Given this list of marker genes Slc20a1, Bhlhe40, Ncl, Anxa2, Nip7, Ctla2a, Abce1, Utp18, Zyx, Ybx3, Tpm4, Reps2, Syncrip, Cct2 (chaperonin containing TCP1 subunit 2), Hsph1, Snhg1, Gjb3, Idh3a, Tpm1, Mphosph6, Usp10, Ctu2, Wdr77, Nsun2, Mak16, Nuak1 (NCBI Gene Id 77976), Ppa1, Esd, Tnfrsf9, AU021092, Ddx21, Timp1, Cdk17, Uchl3, Dpy19l1, Naa25, Lyar, Cycs, Btbd10 (BTB domain containing 10), Myc, Zic4, Cct8, Eif4g1, Gars1, Nolc1 (nucleolar and coiled-body phosphoprotein 1), Pelo, Phgdh, Nae1, Zmiz1, Adissp, Bcat1, Wdr75 (WD repeat domain 75), Klf6, Bmp1, Nin, Rwdd1, Bag2, Tnfrsf12a (NCBI Gene Id 98086), Snx7, 1110038B12Rik, Mmp14 (NCBI Gene Id 17387), Rrm2, Gtf2f2, Msn, Naa15 (N(alpha)-acetyltransferase 15, NatA auxiliary subunit), Tomm20, Pmepa1, Lmln, Sltm, Eif5a, Cacybp, Pum3, Abracl, Ptk2, Eif3b, Pprc1, Gnl3, Ext1, Set, Rsl1d1, Hmga2, Eif2b3, Ptp4a1, Prep, Cdc34, Eif2s2, Cyp1b1, 2700038G22Rik, Kpnb1, Mrto4, Eif5, Actr3 (NCBI Gene Id 74117), Gemin6, Tcp1, Ccn2, Eef1e1, Jade1, Baz1a, Cd44, Ppp1r2, Chd3, Slc8a1, Hspd1, Eif3a, Gadd45g, Mir22hg, Coq10b, Actn1, Gtpbp4, Dlat, Lrp8, Arhgap26, Hspa9, Slc25a5, Mybbp1a, Gcsh, Tomm70a, Srm, Cct3, Eif2s1, Hspe1, Shmt2, Ipo5, Sall1, Zc3h15, Rcc1, Rpf2 (NCBI Gene Id 67239), here is a description of the gene set: from publication Karlsson G, Liu Y, Larsson J, Goumans MJ, Lee JS, Thorgeirsson SS, Ringnér M, Karlsson S (PMID 15769904) Mouse Gene Set: KARLSSON_TGFB1_TARGETS_UP Transforming growth factor-beta1 (TGF-beta) regulates cellular functions like proliferation, differentiation, and apoptosis. On the cell surface, TGF-beta binds to receptor complexes consisting of TGF-beta receptor type II (TbetaRII) and activin-like kinase receptor-5 (Alk5), and the downstream signaling is transduced by Smad and MAPK proteins. Recent data have shown that alternative receptor combinations aside from the classical pairing of TbetaRII/Alk5 can be relevant for TGF-beta signaling. We have screened for alternative receptors for TGF-beta and also for gene targets of TGF-beta signaling, by performing functional assays and microarray analysis in murine embryonic fibroblast (MEF) cell lines lacking Alk5. Data from TGF-beta-stimulated Alk5(-/-) cells show them to be completely unaffected by TGF-beta. Additionally, 465 downstream targets of Alk5 signaling were identified when comparing Alk5(-/-) or TGF-beta-stimulated Alk5(+/+) MEFs with unstimulated Alk5(+/+) cells. Our results demonstrate that, in MEFs, TGF-beta signals exclusively through complexes involving Alk5, and give insight to its downstream effector genes. species: Mus musculus Genes up-regulated by TGFB1 in MEF cells (embryonic fibroblast) via TGFB1R.